The following is a description of a gene set: The directed movement of calcium ions into a cell or organelle. species: Mus musculus Mouse Gene Set: GOBP_CALCIUM_ION_IMPORT, and this is the list of marker genes: Ms4a1, Hes1, Cdk5, Ctnnb1, Lgals3, Cacnb2, Ace, Trpm1, Ucn, Wnk3, Pkd2, Cacna1f, Fyn (NCBI Gene Id 14360), Casr, Slc8a1 (NCBI Gene Id 319418), Pln, Atp2a1, Cacna1h, Slc8a3, Cacna1b, Trpv2, Kcnn4, Plpp4, Ppp3cb, Trpc4, Cacna1i, Cacna1g, Isl1, Crh, Pdgfb, Adrb2, Grm6, Dspp, Ccl12, Wfdc6a, Adrb1, Homer1, P2rx5, Trpv4, Cacna1s, Trpm2, Cav1, Eppin, Cacna1e, Slc24a5, Nalf2, Selenon, Cacna1a, Agtr1a, Slc24a2, Trim27, Cxcl12, Mcur1, Ppp3r2, Atp2c2, Serpine1, Trpv5 (NCBI Gene Id 194352), Gck, Ppp3r1, Pdgfrb, Gcg, Pawr, Prnp, P2rx1, Stc1, Slc24a4, Crhr2, Calhm2, Akap5, Cask, Cxcr4, Cav3, Orai1, Hrh1, Ddit3, Slc8a2, Egf, Trpv3, Strit1, Nalf1, Cacna1d, Trpv1, Slc30a1 (NCBI Gene Id 98435), Spink1, Cacna1c, Itpripl1, Ppp3ca, Micu1, Trpv6, Ppp3cc, Dysf